The following is a description of a gene set: species: Mus musculus The division of a mitochondrion within a cell to form two or more separate mitochondrial compartments. Mouse Gene Set: GOBP_MITOCHONDRIAL_FISSION, and this is the list of marker genes: Spire1, Dcn, Pink1, Mief2, Mapt, Mtfp1 (NCBI Gene Id 69436), Dnm1l, Rala, Ppp2r2b, Prkn, Mir539, Ucp2, Mff, Stat2, Inf2, ENSMUSG00000126352, Lpin1, Cox10, Gdap1, Ddhd2, Cyrib, Mcu, Fis1, Irgm1, Irgm2, Marchf5 (NCBI Gene Id 78729), Tmem135, Mtfr1l, Opa1, Carlr, Ralbp1, Pgam5, Mtfr1, Mfn2, Dhodh, Mtch2, Ap3b1, Slc25a46, Aurka, Bnip3, Vps35, Myo19, Mir361, 4930550C14Rik, Ddhd1, Igtp, Mief1, Mul1, Ppargc1a, Mfn1, Pparg, Ggnbp1, Kdr, Mtfr2